The following is a description of a gene set: Mouse Gene Set: MIR_7A_5P from publication Chen Y, Wang X (PMID 31504780) Genes predicted to be targets of miRBase v22 microRNA mmu_miR_7a_5p in miRDB v6.0 with MirTarget v4 prediction scores > 80 (high confidence targets). species: Mus musculus, and this is the list of marker genes: Nfic, Kcnf1, Cadm3, Anapc11, Ptgfrn, Crebrf, Plekho2, Oxr1, Strn3, Osbpl11, Smarcd1, Dkk3, Smim12, Satb1, Rsbn1l, Cdon, Mobp, Nr4a3 (NCBI Gene Id 18124), Vdac1, Ctsb, H2-Ob, Rgs7bp, Elfn2, Parp1, Tmem88b, Eif4ebp2, Hdlbp, Pilra, Tcf12 (NCBI Gene Id 319985), Klf4, Itch, Cct4, Spopfm2, Slc4a7, Mecp2, Arih1, Rras2, Zbtb4, 9930012K11Rik, Fam53c, Atp10a, Jade1, Xcr1, Kmt5a, Me3, Lsm11, Bicdl2, Zfp93, Fam168a, Ckap4, Rps6kb1, Atp2b2, Sp1, Tbx20, Xpo7, Ssbp2, Slc6a9, Ankrd12, Ids, Faim2, Sh3glb1, Itga4, Pfn2, Ltn1, Zc4h2, Rhbdd1, Ezh1, Mapkap1, Elmo1, Hcn1, Rfx2, Rnf144a, Rnf41, Ghitm, Bcorl1 (NCBI Gene Id 77893), Azgp1, Edar, Susd6, Mapk12 (mitogen-activated protein kinase 12), Mknk1, Nr2c1 (nuclear receptor subfamily 2, group C, member 1), Smg1, Ggt7, Tmed9, Usp40, Psme3, Gdpd4, Pgam5, Cnppd1, Ints10, Slc38a2, Rgs8 (NCBI Gene Id 67792), Tmf1, Ide, Atxn7, Ublcp1, Pan2, Serf2, Snhg11, Rsbn1, Vma21, Dnajc5, Megf9, Ttc14, Kif16b, Med19, Slc25a25 (solute carrier family 25 (mitochondrial carrier, phosphate carrier), member 25), Zfp85, Rnf141, Faxc, Adgrl2, Stxbp6, Klf12, Spata2, Slc16a9, Gkn1, Slc25a23, Adgre4, Jade3, Tmem230, Kdm3b, Aplp2, Gal3st3, Kcna1, Ints7, Stard13, Mafk, Atg3, Nrep, Nipal4, Dgki, Herpud2, Pdha1, Raf1, Nxnl1, Nemp1, Dach1 (dachshund family transcription factor 1), Tex261, B3gnt6, Pik3cd, Pbx3, Gmeb1, Esr2, Gjc1, Fndc4, Ccdc120, Plp2, Mlh3 (NCBI Gene Id 30788), Kif13a, Ogt, Snca, Arid4a, Traf5, Fbxw2, Ddit4, Rb1, Tmco4, Rab5if, Zc3h4, Mcc (mutated in colorectal cancers), Champ1, Chsy3, Chd3, Fbxo28, Marf1, Cntnap1, Srf, Wipf2, Iglon5, Hhip, Frrs1l, Mapk4, Vdac3, Hecw1, Atf7, Trp53inp2, Slc17a1 (NCBI Gene Id 20504), Slc22a23, Wdr47, Tnrc6a, Smyd5, Nr1h2, Zkscan8, Lzts3, Crls1, Bpifa1, Sting1, Plxna1, Ermap, Adcy9, Clasp2, Zbtb22, Plec, Acsl4, Draxin, Ipo11, Fbln7, Gtf2a1, Ambra1, Calu (calumenin), Vps26a (VPS26 retromer complex component A), Zfp609, Cby2, Pom121l2, Prkcb, Slc39a1 (NCBI Gene Id 386471), Socs2, Tmeff2, Pole4, Cat (catalase), Aars2, Adamts8, Pde4a, Fam131b, Bloc1s4, Wfdc1, Mtmr1, Zfp248, Zfp287 (NCBI Gene Id 353040), Ube2q2l, Casp9, Asxl1, Pygo2, Spty2d1, Dync1li2, Pcnx2 (NCBI Gene Id 270109), Cnnm4, Fam168b